The following is a description of a gene set: from publication Cancer Genome Atlas Research Network (PMID 18772890) Human Gene Set: TCGA_GLIOBLASTOMA_COPY_NUMBER_UP studied in species Homo sapiens Genes up-regulated and displaying increased copy number in glioblastoma samples. Human cancer cells typically harbour multiple chromosomal aberrations, nucleotide substitutions and epigenetic modifications that drive malignant transformation. The Cancer Genome Atlas (TCGA) pilot project aims to assess the value of large-scale multi-dimensional analysis of these molecular characteristics in human cancer and to provide the data rapidly to the research community. Here we report the interim integrative analysis of DNA copy number, gene expression and DNA methylation aberrations in 206 glioblastomas--the most common type of adult brain cancer--and nucleotide sequence aberrations in 91 of the 206 glioblastomas. This analysis provides new insights into the roles of ERBB2, NF1 and TP53, uncovers frequent mutations of the phosphatidylinositol-3-OH kinase regulatory subunit gene PIK3R1, and provides a network view of the pathways altered in the development of glioblastoma. Furthermore, integration of mutation, DNA methylation and clinical treatment data reveals a link between MGMT promoter methylation and a hypermutator phenotype consequent to mismatch repair deficiency in treated glioblastomas, an observation with potential clinical implications. Together, these findings establish the feasibility and power of TCGA, demonstrating that it can rapidly expand knowledge of the molecular basis of cancer., and this is the list of marker genes: GATAD1, SOX13, CTDSP2, VPS50, KRIT1 (NCBI Gene Id 9602), NDUFA9, WT1-AS, CAPZA2, MET, PDGFRA, NAGLU, ANKIB1, TSFM, AKAP3, SMC6, LAPTM4A, RDH14, RBM48, CEP170, ADSS2, EIF3M, GEN1, SPMIP3, MDM2, EGFR, SDCCAG8, B4GALNT1, RHOB, PEX1, WT1, CPM, SAMD9, PIK3CA, CYP27B1, SAMD9L, LRRN2, CATSPERE, HS1BP3, ETNK2, MDM4, ZBTB18, HIPK3, FERRY3 (FERRY endosomal RAB5 effector complex subunit 3), KISS1, FAM133B, SLC35E3, METTL1, GOLT1A, PIK3C2B, OS9, RPL21P44, DDX1, SOX2, MYCN, AGAP2, AKT3, AVIL, MIR26A2, QSER1, DYRK4, WDR35, MARCHF9, CHIC2, REN, PLEKHA6, CDK4, CDK6, CCND2, PUM2, PARP11, CSTF3, TSPAN31, TCP11L1, PPP1R15B, LDAH